Given this list of marker genes Pcna, Vcp (valosin containing protein), Rfc3, Rpa1, Rchy1, Ubb, Polh, Rfc1, Sprtn, Ufd1, Rps27a, here is a description of the gene set: part of: Translesion synthesis by Y family DNA polymerases bypasses lesions on DNA template This event has been computationally inferred from an event that has been demonstrated in another species.<p>The inference is based on the homology mapping from PANTHER. Briefly, reactions for which all involved PhysicalEntities (in input, output and catalyst) have a mapped orthologue/paralogue (for complexes at least 75% of components must have a mapping) are inferred to the other species. species: Mus musculus Reactome Pathway: Translesion Synthesis by POLH electronically inferred by orthology from the curated human pathway